Given this list of marker genes IL4R, VAMP7, GATA2, SNX4, FCER1G, SPHK2, PLA2G3, GAB2, IL13, ADORA2B, FGR, VAMP8, GATA1, SYK, STXBP1, here is a description of the gene set: Any process that activates or increases the frequency, rate or extent of mast cell degranulation. Human Gene Set: GOBP_POSITIVE_REGULATION_OF_MAST_CELL_DEGRANULATION studied in species Homo sapiens